The following is a description of a gene set: species: Mus musculus Genes predicted to be targets of miRBase v22 microRNA mmu_miR_7658_5p in miRDB v6.0 with MirTarget v4 prediction scores > 80 (high confidence targets). from publication Chen Y, Wang X (PMID 31504780) Mouse Gene Set: MIR_7658_5P, and this is the list of marker genes: Tmem252, Nfatc3, Sestd1, Jade1, Aplf, Elmod3